Given this list of marker genes Casr (NCBI Gene Id 12374), Nherf1, Abcb4, Ces1b, Ces1g, Stard10, Cldn2, Ces1h, Ces1f, Slc51b, Abcb11, Ces1a, Ces1c, Tnf, Ces1d, Slc51a, Ces1e, here is a description of the gene set: Mouse Gene Set: GOBP_BILE_ACID_SECRETION The regulated release of bile acid, composed of any of a group of steroid carboxylic acids occurring in bile, by a cell or a tissue. studied in species Mus musculus